Given this list of marker genes ATRX, MKS1, MED12, PIK3R1, NAA10, IHH, EZH2, CANT1, GLI3, ALX3, SNORD116-1, COL9A2, CHSY1, CD96, BPNT2, ALG9, FGD1, CRLF1, SF3B4, COL9A1, BCOR, CPLANE1, ESCO2, IFT122, SAMD9 (sterile alpha motif domain containing 9), ROR2, BGN, SNORD115-1, MAGEL2, BMPR1B, MKRN3, SALL4, HERC2, ANKRD11, FLNB, PHGDH, RBM8A, MEGF8, FGFR3, TRAF7, SIN3A, TGDS, CCDC28B, OFD1, SMAD4, ARL6, PWAR1, WNK3 (WNK lysine deficient protein kinase 3), BBS1, BRAF, IGF1R, COL9A3, NPAP1, PTPN11, NOG, FLNA, TRPV4, RECQL4, CILK1, BMP2, MAP2K1, PWRN1, GDF5, TBX5, FGFR2, EIF4A3, ZC4H2, DVL1, CNOT1, SLC26A2, WNT5A, here is a description of the gene set: Human Gene Set: HP_RADIAL_DEVIATION_OF_THE_HAND_OR_OF_FINGERS_OF_THE_HAND Radial deviation of the hand or of fingers of the hand studied in species Homo sapiens